Given this list of marker genes SYNJ2, PIGK, VSTM2L, CDKN2A, ARX, KCNH2, HEPACAM2, TM4SF4, SPTSSB, SPON2, PHGR1, ASGR1, PCSK1, TM4SF5, PEG10, TRNP1 (TMF1 regulated nuclear protein 1), NUAK1, SUCNR1, DEFB1, ANXA13, SAMD5, ACSL1, SERPINA1, EBF1, SERPINA10, SEMA3E, BMP7, CLU, NEDD9, FFAR4, TMEM45B, DIRAS3, FRZB, VTN, ASAH1, FAXDC2, GHRL, PROX1, SERPINB6, LINC00261, FGF14, AGT, ZKSCAN1, SPINK1, here is a description of the gene set: species: Homo sapiens from publication Muraro MJ, Dharmadhikari G, Grün D, Groen N, Dielen T, Jansen E, van Gurp L, Engelse MA, Carlotti F, de Koning EJ, van Oudenaarden A (PMID 27693023) Human Gene Set: MURARO_PANCREAS_EPSILON_CELL